The following is a description of a gene set: Mouse Gene Set: GOBP_POSITIVE_REGULATION_OF_PROTEIN_NEDDYLATION species: Mus musculus Any process that activates or increases the frequency, rate or extent of protein neddylation., and this is the list of marker genes: Dcun1d5, Dcun1d1, Dcun1d4, Dcun1d3 (NCBI Gene Id 72260), Tes3-ps, Dcun1d2